The following is a description of a gene set: Human Gene Set: REACTOME_INACTIVATION_OF_CSF3_G_CSF_SIGNALING Inactivation of CSF3 (G-CSF) signaling studied in species Homo sapiens, and this is the list of marker genes: SOCS3, CUL5, ELOB, ELOC, STAT3, TYK2, CSF3 (colony stimulating factor 3), RPS27A, JAK1, CSF3R, UBB, SYK, STAT5B, JAK2, STAT5A, UBA52, UBE2D3, SOCS1, UBE2D2 (ubiquitin conjugating enzyme E2 D2), UBE2D1, UBC, STAT1, HCK, RNF7, LYN